Given this list of marker genes DKK2, ADH7, WFIKKN2, DKK3, ESR2, IL18BP, IL1RN, IGSF1, DKK4 (NCBI Gene Id 27121), LRPAP1, FST, CCL5, DKK1, AGTR2, PXDN, DKKL1 (dickkopf like acrosomal protein 1), WFIKKN1, IL36RN, here is a description of the gene set: studied in species Homo sapiens Human Gene Set: GOMF_RECEPTOR_ANTAGONIST_ACTIVITY The activity of a gene product that interacts with a receptor to decrease the ability of the receptor agonist to bind and activate the receptor.